Given this list of marker genes Ptpn18, Hras, Egfr, Matk, Btc, Erbb4, Yes1, Memo1, Ptpn12, Shc1, Prkca, Erbb2, Rps27a, Cdc37, Nrg3, Fyn, Grb2, Ubb, Gab1, here is a description of the gene set: part of: Signaling by Receptor Tyrosine Kinases electronically inferred by orthology from the curated human pathway species: Mus musculus This event has been computationally inferred from an event that has been demonstrated in another species.<p>The inference is based on the homology mapping from PANTHER. Briefly, reactions for which all involved PhysicalEntities (in input, output and catalyst) have a mapped orthologue/paralogue (for complexes at least 75% of components must have a mapping) are inferred to the other species. Reactome Pathway: Signaling by ERBB2